The following is a description of a gene set: Reactome Pathway: Cell Cycle Checkpoints part of: Cell Cycle <p>A hallmark of the human cell cycle in normal somatic cells is its precision. This remarkable fidelity is achieved by a number of signal transduction pathways, known as checkpoints, which monitor cell cycle progression ensuring an interdependency of S phase and mitosis, the integrity of the genome and the fidelity of chromosome segregation.</p><p>Checkpoints are layers of control that act to delay CDK activation when defects in the division program occur. As the CDKs functioning at different points in the cell cycle are regulated by different means, the various checkpoints differ in the biochemical mechanisms by which they elicit their effect. However, all checkpoints share a common hierarchy of a sensor, signal transducers, and effectors that interact with the CDKs.</p><p>Depending on the stage of the cell cycle that they regulate, the cell cycle checkpoints are divided into G1/S checkpoints, S phase checkpoints, G2/M checkpoints, and M/G1 checkpoints. There are a number of documented genetic lesions in checkpoint genes, or in cell cycle genes themselves, which result either directly in cancer or in a predisposition to certain cancer types. Indeed, restraint over cell cycle progression and failure to monitor genome integrity are likely prerequisites for the molecular evolution required for the development of a tumor. Perhaps most notable amongst these is the TP53 (p53) tumor suppressor gene, which is mutated in >50% of human tumors. Thus, the importance of the checkpoint pathways to human biology is clear.</p> studied in species Homo sapiens, and this is the list of marker genes: CDKN1A, PSMC1, CDC6, ORC6, PPP2R5E, H2BC12, TP53, CCNE2, PAFAH1B1, WEE1, MRE11, MIS12, ATRIP, ADRM1, PSMD8, PSMB7, PSMA2, KIF18A, SPC24, MAD1L1, CLSPN, MDM2 (MDM2 proto-oncogene), NDEL1, DYNC1LI2, PSMD14, NUF2, PSMB6, RNF8, CSNK1E, CENPT, ZWILCH, H4C1, MDC1, DYNLL2 (NCBI Gene Id 140735), PSMA5, PSMD6, PSMB5, BRCA1, PPP1CC, MCM7, ATM (ATM serine/threonine kinase), KIF2A, UBE2N, HERC2, ORC1, KAT5, H2BC17, AHCTF1, BUB3, UIMC1, UBE2C, MCM2, H3-4, MAPK11, PSMC4, YWHAB, RPA1, YWHAG, SGO2, NUP133, SKA2, EXO1, CDKN1B, PSMB3, XPO1, PSMA4, PHF20, H2BC3, NSL1, H2BC13, MDM4, NDC80, CDK1, PSMC3, GSK3B, PSMA1, MCM8, H2BC12L (NCBI Gene Id 54145), PPP2R5B, RMI1, CSNK1A1, DYNLL1, AURKB, ATR, RNF168, CENPN, CCNB2, ANAPC4, ANAPC5, ERCC6L, H2BC4 (NCBI Gene Id 8347), YWHAH, ANAPC16, RAD17, PSMB4, SPC25, PPP2R5A (NCBI Gene Id 5525), PMF1, BUB1B, GTSE1 (G2 and S-phase expressed 1), CDC25A, BABAM2, DNA2, H2BC5, NUP85, H2BC26, SEH1L, PLK3, ANAPC10, RBX1, MCM5 (NCBI Gene Id 4174), CENPF, CENPA, ANAPC15 (NCBI Gene Id 25906), CENPS, PSMA3, BLM, CDKN2A, PSMD11, H2BC1, YWHAE, CCNA1, SKA1, KNL1 (kinetochore scaffold 1), NUP98 (nucleoporin 98 and 96 precursor), ANAPC11, CDC16, RFC4, RAD50, B9D2, SPDL1, PPP2R5D, PSMC2, MCM4, RBBP8, MAPK14, CENPL, CLASP2, PCBP4, PSMA7, ANAPC7, RPS27A, PSMD13, BRIP1 (NCBI Gene Id 83991), UBE2V2, CDC45 (cell division cycle 45), MCM3, MAPRE1, UBE2D1 (ubiquitin conjugating enzyme E2 D1), PSMD2 (proteasome 26S subunit ubiquitin receptor, non-ATPase 2), TP53BP1, BABAM1, KIF2B, CDC25C, FBXW11, SEC13, RAD1 (RAD1 checkpoint DNA exonuclease), ZW10, H2BC14, SKP1, CDC20, BTRC, RPA3, YWHAQ, PSMB2, KIF2C, NUP107, UBE2S, PSMD7, ORC5, HUS1, H2BC9, UBB, UBC, ANAPC1, PPP2R5C, CKAP5, NSD2, TOP3A, H2BC11, RPS27, CCNA2, SGO1, CHEK1, NUP37, PPP2R1A, CDC27, BRCC3, DSN1, CENPM, H2BC15, PSMC5, NDE1, PSMB1, NBN, RFC5, PPP2CA, CDCA8, PPP2R1B, ITGB3BP, RMI2, CDC23, CUL1, NEK11, TOPBP1, CLIP1, ZNF385A, PSMA6, MCM10, SFN, CENPC, H2AX, NUP160, H2BC21, TAOK1, PSMD12, RCC2, UBE2E1, CLASP1, RHNO1, CENPI, PSMD3, CCNE1, CHEK2, PKMYT1, ORC2, ANAPC2, ORC4, RPA2, PSMD1, CDC26, DBF4, RANBP2, DYNC1I2, RANGAP1, RAD9A, PSMC6, UBA52, DYNC1H1, BARD1, PLK1, CDK2, BUB1, CENPQ, CENPE, NUDC, MCM6, CENPU, RFC2, WRN, CENPP, CDC7, ZWINT, DYNC1I1, COP1, RAD9B, PPP2CB, SEM1, RFC3, PIAS4, ORC3, INCENP, CCNB1, ABRAXAS1, CENPK, BIRC5, KNTC1, CENPH, DYNC1LI1, YWHAZ, NUP43, CENPO, MAD2L1